The following is a description of a gene set: The cellular component assembly that is part of the initial shaping of the component during its developmental progression. Human Gene Set: GOBP_CELLULAR_COMPONENT_ASSEMBLY_INVOLVED_IN_MORPHOGENESIS studied in species Homo sapiens, and this is the list of marker genes: OBSCN, TBC1D20, TPM1, MTMR2, ANK2, TTN, MEF2A, EDN1, ITGB1 (integrin subunit beta 1), PMP22, CSRP2, SMAD4, NECTIN2 (NCBI Gene Id 5819), CD9, UGT8, TPPP (NCBI Gene Id 11076), PDGFRB, GPC1, MYL9 (NCBI Gene Id 10398), MYL2, IHH, FLII, CYLC1, MYBPH, PLN, ANKRD23, MIR1-1, MFSD14A, PROX1, DCAF17, MYOM2, ITGB4, CCDC136, TMOD2, FLNC (NCBI Gene Id 2318), MYOM3, PALS1, CASQ1, ACTG1, NEBL, PAFAH1B1, MAG, PRKD1, ACRBP, TMOD4, VPS13B, CAPN3, ABCA2, ACTA1, PFN4, ACTL9, AGFG1, GARIN1A, TENM4, PLLP, CSRP3, KLHL41, ERCC2, SPINK2, MYBPC1, ACTN2, LDB3, TMOD3, PDGFRA, GARIN3, PDCL2, CFLAR, MYLK3, CFL2, MYOZ2, OBSL1, FIG4, RFX2, LMOD2 (NCBI Gene Id 442721), MIOS, NKX2-5, CNTNAP1, FHOD3, TBPL1, CHN2, SYNPO2L, CSRP1, SIX4, MYOM1, TMPRSS12, EPB41L3, PLEC, NEB (NCBI Gene Id 4755), GARIN1B, BMP10, ACTL7A, SOX30, MYPN, TNNT1, NRAP, PLA2G3 (phospholipase A2 group III), CCDC42, MYH3, MYBPC3, ACTC1, SRF, AGFG2, LMOD3, LMOD1, KIAA0319L, SPACA1, TMF1, PRKAR1A, CNTN1, POC1B, CAV3, TCAP, CCDC38, WDR1 (WD repeat domain 1), TMOD1 (tropomodulin 1), NCMAP, MYBPC2, MYH10, MYH11, GNPAT, SPPL2C, KNL1, ANKRD1, TNNT2, PGM5, KRT19, MYH6, MYOZ1, ZPBP2, TNNT3, IZUMO3, ADPRHL1, SLC9A8, DICER1, AKAP13, ZPBP